Given this list of marker genes BMPR1B, GDF2, ZFYVE16, RARA, BMP10, YBX1, CHRDL1, RBL1, UBC, FGF2, ITGAV, APH1B, XPO1, MTMR4, AGO2, SNW1, CCNC, ITGB8, MYOD1, TNRC6B, LTBP1, BMP2, PPM1A, STUB1, ACVR2B, BAMBI, SKIL, NEDD4L, MOV10, UBE2M, INHBB, PARP1, LTBP3, BMPR1A, ITGB3, UBB, SMAD6, CER1, NEDD8, PRKCZ, HDAC1, SMAD9, RXRA, MEN1, TNRC6A, MYF6 (NCBI Gene Id 4618), CCNT2, MIR23B, ARHGEF18, ITGA8, PPP1R15A, TGFBR2, UBA52, MYOG, GREM2, PSEN2, LTBP2, TGFB2, RNF111, ACVRL1, MYCN, NCOR1, UBE2D3, LTBP4, E2F4, STAT1 (NCBI Gene Id 6772), SMAD1 (SMAD family member 1), FST, USP15, ACVR1C, DRAP1, AMH, ACVR1B, ZFYVE9, MYF5, FURIN (furin, paired basic amino acid cleaving enzyme), COL1A2, AGO3 (NCBI Gene Id 79910), MAPK1, FKBP1A, NOG, TCF12, UCHL5, F11R, SP1, TGFB1, PPP1CA, TFDP1, MIR27B, ITGB1, SMAD5, TGFB3, NCOR2, MIRLET7A1, TRIM33, TGIF2, PPP1CC, ACVR2A, AGO4, EP300, JUNB, SMAD4, NCSTN, RHOA, FSTL1, PARD6A, TNRC6C, TGFBR1, MYC, CDK9, SMURF2, TGIF1, TIMP2, SMAD7, E2F5, PSENEN, PARD3, CCNK, TGFBR3 (NCBI Gene Id 7049), TCF3 (transcription factor 3), TIMP1, ARRB1, INHBA, STRAP, SMAD3, MMP16, ARRB2, ITGB6, HELLS, RPS27A, ATP1B4, CGN, USP9X, FSTL3, SMURF1, TFDP2, PSEN1, SKI, MAPK3, CCNT1, UBE2D1, AMHR2, AGO1, CDKN2B, BMPR2, CDK8, GIPC1, FOXH1, PMEPA1, INHA, KLF16, WWTR1, TCF4, APH1A, SMAD2, PPP1CB, FBN1, ITGB5, SERPINE1, MMP14, CBL, here is a description of the gene set: part of: Signal Transduction Reactome Pathway: Signaling by TGFB family members The human genome encodes 33 TGF-beta family members, including TGF-beta itself, as well as bone morphogenetic protein (BMP), activin, nodal and growth and differentiation factors (GDFs). This superfamily of ligands generally binds as dimers to hetero-tetrameric cell-surface receptor serine/threonine kinases to activate SMAD-dependent and SMAD-independent signaling.<br>Signaling by the TGF-beta receptor complex is initiated by TGF-beta. TGF-beta (TGFB1), secreted as a homodimer, binds to TGF-beta receptor II (TGFBR2), inducing its dimerization and formation of a stable hetero-tetrameric complex with TGF-beta receptor I homodimer (TGFBR1). TGFBR2-mediated phosphorylation of TGFBR1 triggers internalization of the heterotetrameric TGF beta receptor complex (TGFBR) into clathrin coated endocytic vesicles and recruitment of cytosolic SMAD2 and SMAD3, which act as R-SMADs for TGF beta receptor complex. TGFBR1 phosphorylates SMAD2 and SMAD3, promoting their association with SMAD4 (known as Co-SMAD). In the nucleus, the SMAD2/3:SMAD4 heterotrimer binds target DNA elements and, in cooperation with other transcription factors, regulates expression of genes involved in cell differentiation. For a review of TGF-beta receptor signaling, please refer to Kang et al. 2009.<br> Signaling by BMP is triggered by bone morphogenetic proteins (BMPs). BMPs can bind type I receptors in the absence of type II receptors, but the presence of both types dramatically increases binding affinity. The type II receptor kinase transphosphorylates the type I receptor, leading to recruitment and phosphorylation of SMAD1, SMAD5 and SMAD8, which function as R-SMADs in BMP signalling pathways. Phosphorylated SMAD1, SMAD5 and SMAD8 form heterotrimeric complexes with SMAD4, the only Co-SMAD in mammals. The SMAD1/5/8:SMAD4 heterotrimer regulates transcription of genes involved in development of many tissues, including bone, cartilage, blood vessels, heart, kidney, neurons, liver and lung. For review of BMP signaling, please refer to Miyazono et al. 2010.<br>Signaling by activin is triggered when an activin dimer (activin A, activin AB or activin B) binds the type II receptor (ACVR2A, ACVR2B). This complex then interacts with the type I receptor (ACVR1B, ACVR1C) and phosphorylates it. The phosphorylated type I receptor phosphorylates SMAD2 and SMAD3. Dimers of phosphorylated SMAD2/3 bind SMAD4 and the resulting ternary complex enters the nucleus and activates target genes. For a review of activin signaling, please refer to Chen et al. 2006. species: Homo sapiens